Given this list of marker genes Lrrc14, Nfkbia, Ubb, Ager, Rps27a, Ube2v1, Tab2, Hmgb1, Rela, Tab3, S100b, Nkiras1, Nlrx1, Nfkb2, Ikbkb, Nfkbib, Tifa, Ube2n, Nfkb1, Nlrc5, Casp8, Tab1, Irak1, here is a description of the gene set: electronically inferred by orthology from the curated human pathway part of: Interleukin-1 signaling; MyD88 cascade initiated on plasma membrane; MyD88:MAL(TIRAP) cascade initiated on plasma membrane; TRAF6 mediated induction of NFkB and MAP kinases upon TLR7/8 or 9 activation; TRIF (TICAM1)-mediated TLR4 signaling ; Toll Like Receptor 3 (TLR3) Cascade This event has been computationally inferred from an event that has been demonstrated in another species.<p>The inference is based on the homology mapping from PANTHER. Briefly, reactions for which all involved PhysicalEntities (in input, output and catalyst) have a mapped orthologue/paralogue (for complexes at least 75% of components must have a mapping) are inferred to the other species. studied in species Mus musculus Reactome Pathway: TAK1-dependent IKK and NF-kappa-B activation